Given this list of marker genes FEZF2, SEMA5A, RTN4, EPHB2, CNTN2, EPHB3, CASP3 (caspase 3), NRCAM, NRP1, TNFRSF21, EPHA3, EPHA4, ARHGAP35, CRTAC1, AMIGO1, NDN, CNTN4, NCAM2, CDK5R1, MEGF8, CNR1, here is a description of the gene set: Human Gene Set: GOBP_AXONAL_FASCICULATION studied in species Homo sapiens The collection of axons into a bundle of rods, known as a fascicle.